Given this list of marker genes PNLIPRP1, PLA2G15, LIPC, PLA2G4C, LPL, PLA2G4B, PLA2G4E (phospholipase A2 group IVE), PLAAT5, PLAAT4 (NCBI Gene Id 5920), PNLIP, LIPG, DDHD1 (NCBI Gene Id 80821), ABHD3, PLAAT1, PLA2G4F, PLA1A, PLAAT2, PLAAT3, PNPLA8, PNLIPRP3, PLA2G4D, PNLIPRP2, here is a description of the gene set: Catalysis of the reaction: a 1,2-diacyl-sn-glycero-3-phosphocholine + H2O = a 2-acyl-sn-glycero-3-phosphocholine + a fatty acid + H+. studied in species Homo sapiens Human Gene Set: GOMF_PHOSPHOLIPASE_A1_ACTIVITY